The following is a description of a gene set: Mouse Gene Set: GOBP_ERYTHROCYTE_HOMEOSTASIS species: Mus musculus Any process of regulating the production and elimination of erythrocytes within an organism., and this is the list of marker genes: Tspo2, Gm15915, Mpig6b, Nemp1 (NCBI Gene Id 72243), Rb1, Ankle1, Ahsp, Nckap1l, Klf2, Hmga1, Stat5a, Atp5if1 (ATP synthase inhibitory factor subunit 1), Bmp4, Jmjd6, Mir451b, Casp3, Ets1, P4htm (prolyl 4-hydroxylase, transmembrane (endoplasmic reticulum)), Ankrd54 (NCBI Gene Id 27619), Lyar, Nfe2l1, Bap1, Smarca4, Ufl1, Dyrk3, Hoxa5 (NCBI Gene Id 15402), Rps6, Hspa9, Isg15, Zbtb7a, Slc4a1, Jak2, Slc48a1, Foxo3, Hnrnpu, Epb42, Hoxb6, Epas1, Cdk5rap3, Brd1, Mapk14, Rps19, Inhba, Rps14, Trim58, Kcnq1, Tmod3, Ncapg2, Vps13a, Rac1, Hif1a, Dnase2a, Senp1, Zfpm1, Lyn, Exoc6, Id2, Mir125a, Kat7, Abcb10, Etv2, Ptpn2, Tgfbr3, Arid4a (NCBI Gene Id 320602), Myb, Inpp5d, Kit, Thra, Rhd, Racgap1, Hspa1b, Stat3, Rbfox2, Maea, Fech, Mfhas1 (NCBI Gene Id 71940), Zfp36, Zfp36l1, Hba-x, Smad5, Alas2, Srf, Slc11a2, Cdk6, Mir451a, Gata1, Ampd3, Bpgm, Rcor1, Ikzf1, Hbb-bs, Prkdc, Heph, Gata3, B2m, Kmt2e, Mir144, Bcl6, Spi1, Stat5b, Hba-a1, Slc25a5, Med1, Hba-a2, Klf1, Ireb2, Klf13, Epo, Sp3, Ank1, Adgrf5, Mb, Hcls1, Slc25a40, Mafb, Plcb1, Slc25a38, Chmp5, Acvr1b, Gfi1b, Slc1a5, Scnn1b, Sp1, Tal1, Sh2b3, Alas1 (NCBI Gene Id 57445), G6pd2, Flvcr1, Ldb1, Ypel4, Ncor1, Diaph3, Uba5, Rps17, Mir122, Prmt1, Rac2, Rps24, Cdin1, Lmo2, Prdx1, Glul, Add1, Axl, Cebpg, Tmem14c, Hmox1, Acin1, Sfxn1, Cd24a, Stat1, Gata2, Cited2, Ptbp3, Pknox1 (Pbx/knotted 1 homeobox), Bbip1, Axin1, Heatr3, L3mbtl3, Kdm1a, Fam210b, Tcf3, Rhag, Ercc2, Vegfa, Adar, Dmtn, Trim10 (NCBI Gene Id 19824), Setd1a, Bbs4, Hmgb2, Selenow, Adgrf4, Gpi1, Hdac6, Bloodlinc, Hscb, Smap1, Tcea1, Sox6, G6pdx, Acvr2a, Pla2g10, Ehbp1l1